The following is a description of a gene set: Human Gene Set: MIR580_5P Genes predicted to be targets of miRBase v22 microRNA hsa-miR-580-5p in miRDB v6.0 with MirTarget v4 prediction scores > 80 (high confidence targets). studied in species Homo sapiens from publication Chen Y, Wang X (PMID 31504780), and this is the list of marker genes: ALB, SMARCC1, HMGCLL1, BTBD8, KCTD6 (NCBI Gene Id 200845), GUCY1A2, GPHN (NCBI Gene Id 57566), PAPOLG, KLRC1, ZDHHC21, KICS2, WFDC8, SUZ12, RAP1B (NCBI Gene Id 5908), TMEM59, PINX1, BORCS7, DNHD1, G2E3, TAP2, FRS2, ING2, EIF1B, PAK2, NDUFB4, TRPM8, TRIM49, CCL28, SH3BP5, EHHADH, CD164, RAB33B, VPS13C, TJP1, LDLRAD4, CERT1, IREB2, FAM210A, PHF3, SRSF10, CEP170B, QNG1, DDI1, ERAP1, TNNT1, KCMF1, CLINT1, TET1, MCTP1, BAZ2B, HIPK1, STAG2, ZBTB10 (zinc finger and BTB domain containing 10), FLT1, RUNX1T1, SLCO4C1 (NCBI Gene Id 55385), WAPL, ZNF326, ZFAND6, NSD3, SNX5, RAB27B, TSPYL1, ECHDC1 (ethylmalonyl-CoA decarboxylase 1), SLC10A2, EXT2, SNX3, CTNNA2, TECTB, B3GALT2, CUL3, SLITRK3, ZIC4, ELOVL7, RCOR3 (REST corepressor 3), ELOVL5, COMMD3-BMI1, TOR1AIP1, SIPA1L1, FBXW2, RNMT, ZNF382, CLDN10, HMGN3, XG, PDCD4, HECTD1, SYCP2, RNF44, NBEAL1, KIAA1143, SLC10A7, ZNF100, ZC3H13, PSMA1, STEAP2, SF3A1, CCDC141, PEX3, ZNF860, MTCH2, DICER1, XRRA1, SPIN4, IL17D, CEP162, SLC1A3, FAM111B, FGFR2, L3HYPDH, POLK, KIF13A, ANKS1B, SUCLA2, MTX3, AHCYL1, GRPEL2, PTPN13, CPEB3, AMMECR1, MYO1B, TM9SF4, PRRG1, TMEM47, PER3, ZNF761, TRIM49C, RNF38 (NCBI Gene Id 64796), HAL, FZD3, ST13, NDFIP1, KLRC2, RBFOX1, VTI1A, PDE12, JADE1, CYB561D1, ZNF765, ZDBF2, H2BC12 (H2B clustered histone 12), STRN, MFSD4A, PTPRG, CDX1, USP51, SMARCAD1, ERCC6, CMPK1, ZNF648, SLC8A3, INO80, ZNF131, PIAS2, MTMR4, C14orf39, KRAS, RSBN1, PRKAR2B, KIF5B, COX18, EMP2, TRIM2, ATP1B4, NARS2, GJC1 (gap junction protein gamma 1), NAA50, ZNF577, SSBP2, HNRNPA0, KCNV2, BOC, DSCC1, FAM216A, C8orf33, PTER, ALG10B, TREM1, MBTPS2, SPTSSA, GRIK2, CIAO2A, MED6, GMCL1, ZFYVE16, PDSS2, ARHGAP36, RNH1, HCN1, TAT, ADAM10, TOP1 (DNA topoisomerase I), ABRAXAS2, ATF2, RHOBTB1, TRAF3IP1, TTC3 (tetratricopeptide repeat domain 3), COL25A1, CDC14B, CNOT7, ELOVL2, ZMYND11, CYP3A7, AMOT, DLGAP4, ZC4H2, ADAM28, NGF, PPDPFL (NCBI Gene Id 492307), HEMGN, RAB6C, SSPN, UBE2W, ELF1, HSPA9, DNAJC13, ACSL3, NEDD9, KMT5B, LAMB4, SPRED1, MAPK1, SSTR1, BARD1, LCORL, ZBTB20, ANKRD33B, NOVA1, SKAP2, VWC2, FAM216B, ZC3H12C, GARRE1, CERS6, SHPRH, SLC25A24, SNAP25, INO80D